The following is a description of a gene set: Neighborhood of CSNK1D Human Gene Set: MORF_CSNK1D species: Homo sapiens Neighborhood of CSNK1D casein kinase 1, delta in the MORF expression compendium, and this is the list of marker genes: RASSF7, GPR35, NELFB, MKRN1, STK19, SLC9A1 (NCBI Gene Id 6548), SLC25A36, FAM89B, SDR39U1, TIAL1, STAT3 (signal transducer and activator of transcription 3), ZC3H3, CNP, IKBKG, RABAC1, TPR (NCBI Gene Id 7175), MGAT1, SRRT, SS18, TERF2IP, DDB1, MRPL28, MORC3 (NCBI Gene Id 23515), RPRD2, SFSWAP (NCBI Gene Id 6433), PCBP3, PHB1, NUDT3, METAP1, ARPC4, BECN1, RAB1A, ADAM15, GFUS, PRKCSH, PML, AGPAT1 (1-acylglycerol-3-phosphate O-acyltransferase 1), DHRS1 (dehydrogenase/reductase 1), SH2B1 (SH2B adaptor protein 1), KDM5C, CHD8, B4GALT3, CIB1, OTUB1, NAP1L4, PARN, RAF1, LSM12, POLR2A (NCBI Gene Id 5430), ZBED1, PRKAG1, ATG9A, RNF103 (ring finger protein 103), BRD3, ALDH4A1, MFN2, TUBGCP2, PCGF1, EML3, PLIN3, BAHD1, MR1, CSNK1D, ZFTRAF1, PCGF2, RABGGTA (NCBI Gene Id 5875), NFYB, ST14, PPP1R10, KHNYN, MTX1